The following is a description of a gene set: species: Homo sapiens Cell interactions in pancreatic cancer microenvironment Human Gene Set: WP_CELL_INTERACTIONS_IN_PANCREATIC_CANCER_MICROENVIRONMENT, and this is the list of marker genes: LAG3, VEGFA, FAS, NRP1, KDR, BAG3, CCL5, CXCL12, CD80, ITGB6, CD86, CCR5, CCL2, CXCR3, CSF2, FASLG, CTLA4, CXCL10, CSF1, IFITM2, CSF2RA, HLA-DRB1, CXCR4, HLA-DRA, TGFB1, CCR2, CSF1R